The following is a description of a gene set: Human Gene Set: GOBP_REGULATION_OF_ANATOMICAL_STRUCTURE_SIZE species: Homo sapiens Any process that modulates the size of an anatomical structure., and this is the list of marker genes: SLIT2, BAG4, PRKCD, ZFYVE27 (zinc finger FYVE-type containing 27), NTS, TMOD1, ABCC9, SLC12A3, CYFIP2, DOCK5, SERPINF2, ARHGAP5, IRAG1, FGB, HTR2A, CDC42EP5, CDC42EP1 (NCBI Gene Id 129136), TRIM46, CLASP2 (NCBI Gene Id 440948), HCK, APLN, HNF1B, WAS, CCDC51, CFL1, F2RL1, ACTN2, SEMA3F, HCLS1, WASHC5, KXD1, NEB, NGF, AVPR2, PAX2, AVIL, FCHSD2, EXT2, ECE1, BDKRB2, LARS1, SLC8A1, PTPN11, ADD1, GRIP2, SMTNL1, ASXL1, LPAR3, NOS1, ADORA1, CYRIB, BLOC1S1, RAB3B, ISLR2, PAK1, SPTA1, LRRC8A, TRPV4, CPS1, AKT3, PEX11A, MAPT, PER2, ACE2, C15orf62, ROCK1, ARHGAP4, MAP3K13, SLC12A8, TBXA2R, SSH2, PLEK, DRD5, LEP, SOD2, KCNJ8, SEMA3A, RB1CC1, SSH1, MAP2, BLOC1S2, HTR2B, FCHSD1, GCLC, BARHL2, ITGB1BP1, AVPR1A, PLOD3, PECAM1, SWAP70, RAP1GDS1, VILL, KCNA5 (NCBI Gene Id 3741), GOLGA4, TMOD3 (NCBI Gene Id 29766), KIRREL1, FSTL4, KCNMA1, AVP, GSN, SPECC1L, MTNR1B, SOD1, NOS3, SRF, RTN4R, ARHGAP42, KAT2B, GAB1, GCLM, FGF13, CAPZA2, TNFRSF12A, NCK2, NCK1, MAP3K7, ADRB3, ANO6, L1CAM, CDH1, NCKAP1L, SLC12A4, INS, VEGFA, SCT, S100A1, SLC12A6, CCL21, AGT (angiotensinogen), RPTOR, SEMA6C, TBXAS1, MTOR, CAPZA1, ARPC2, ARHGAP28, ARHGAP40, PLEKHH2, P2RY1, RET, MSN, LRRC8E, PREX1, ANAPC2, CXCL12, LMOD1, SCIN, FGA, ARF6, SVIL (NCBI Gene Id 6840), SPTBN4, HRH2, AKT1S1, SEMA6D, LAMTOR4, WDR1, GPX1, TSC1, SCNN1B, SPTB, NTRK3, CARMIL2, SPTAN1, ADD3, SLC12A1, SPART, CASR (NCBI Gene Id 846), LMOD2, LRRK2, STK39, SLC12A7, BAIAP2L2, BAIAP2, FER, EFNA5, CDKL3, FOXC2, CDC42EP4, MMP2 (NCBI Gene Id 4313), MIR214, IQGAP3, ADCY6, WNT5A, RIN3, SLC26A5, RASA1, DISC1, IFRD1, NAA80, ADORA2A, ATP13A2, GBA2, ACE, SLC12A5, FOXC1, SCARB1, GPRC5B, ATP2B1, CALCA, KDM1A, ADCY10, ADRA1A, RGMA, SNX9, TENM1, MIR138-1, IL7R, SLC12A2 (solute carrier family 12 member 2), RNF6, SLC12A9, P2RY2 (NCBI Gene Id 5029), MIR92A1, NPPB, CAV3, SCPEP1, ARFGEF1, EDNRB, GSK3B, PLXNA3, MYO3A, BMPR2, HBB, CDHR2, DNM2, PPARD, KCNMB2, ZDHHC21, SPTBN1, KLF2, SEMA3G, CLCN6, ALS2 (NCBI Gene Id 65058), DRAXIN, KANK2, COTL1, VIL1, ASB2, KEL, CDH4, RAP1GAP2, EPS8, CCL24, NPPA, KIAA0319, LAMTOR5, NPR1, HIP1R, TWF1 (NCBI Gene Id 82712), CAPZA3, UTS2B, ADRB1, DAAM2, WASHC2C, USH1C, ULK1, CNTN2, DLG1, EVL, ADRA2C, SEMA4F, BORCS5, NEFL, SH3BP1, IST1, MTPN, SLIT1, ITGA1, MLST8, CARMIL1, MAS1, ITGA9, RHOA, SEMA4D, SSH3, MRGPRD, P2RX1, HTR1D, ARPC5, ADM, PIK3C2A, SPP1, ADORA2B, FAAH, FSHR, DMTN, GNB3, KCNN4, NHERF1, ACTA2, STUB1, RARG, AVPR1B, AQP4, ROCK2, SNAPIN, CYFIP1, FN1, POU4F2, ARPC3, AGTR2, MEGF8, CCL11, PIK3R2, BCL11A, NKX6-1, MANF, DNAJC16, SEMA5A, BORCS8, PLXNA4, SLC6A4, RYK (receptor like tyrosine kinase), PRKD1, EZR, TMOD4, ATG5, DBH, RAB5A, ELN, WNT3A, KANK1, HSP90AA1, MACF1, SRC, CDKL5, RICTOR, BBS2, F2R, TRIOBP, CD38, DSCAM, ATP1A2, RGS2, BDNF, GRB2, RAB22A (NCBI Gene Id 57403), PTEN, HTR7, WNT7A, PTPRS, AGTR1, CDHR5, RTN4, XK, MAP1B, TWF2, TNR, PYCARD, SHTN1, KANK4 (NCBI Gene Id 388637), CRABP2, TACR1, MYADM, OLFM1, DEPTOR, MKKS, HTR1B, DRD1, RUFY3, UTS2R, ELAVL1, WNK1, NPPC, ARHGAP18, NPHS1, PDXP, PUM2, KCNMB4, CRACD, MYO3B, MAP2K1, ARPC5L, WNT3, ITGB1, VASP, HRH1, FLII, MIR21, DIP2B, KNG1, HDAC6, ALOX15, CDC42EP3, VAV3, SVEP1, GJA5, UCN, GPER1, PEX11B, BORCS6, CLCN3, BRK1, VSTM4, UTS2, BAIAP2L1, DNM1, AP2M1, CAV1, ASIC2, NRP1, RDX, APOE, WNT9B, CLN8, ADRA1B, ADNP, BIN1, EPHA7, EDN3, WNT7B, RAC1, PLEKHG2, HTR1A, COL6A1, ADRA1D, LIMK1, NRCAM, NTN1, DCC, ADRA2A (adrenoceptor alpha 2A), WNK3, CYRIA, OXSR1, LATS1, BBS4, CHMP3, ENSG00000274276, CAPG, BORCS7, WDTC1, SIN3A, ABCB8, CORO1A, TP73, ADRB2, PTK2B, ITGA4, TMSB4Y, RAB21, MAG, TMOD2, PRR16, GDI1, LMOD3, SPTBN5, KCNK6, TNF, ULK2, SPTBN2, CLNS1A, ARHGAP35, SMURF1, NCKAP1, PLS1, HP1BP3, CFL2, ADRA2B, AQP11, PFN3, CCL26, CDK5, FGG, COMP, MT3, PFN1, EDNRA, EDN2, PRKCE, EDN1, PAFAH1B1, RND2, ABITRAM, GUCY1A1, NPM1, PFN2, PICALM, E2F4, VAV1, KANK3, CBS, ADD2, ESAM, CTTN, PAK3, PRKG1, ABL1, TRPM4, BLOC1S6, PEX11G, CAPZB, CCR7, TMSB4X, HNF1A, AMOT, P2RX7, VAV2, PIK3CA, CLN3, TRPC5 (NCBI Gene Id 7224), SCTR, TTL, HAX1, MIR153-1, CDC42EP2, CSF3, DOCK4, TRPV2, DSTN (destrin, actin depolymerizing factor), OXTR, CREB1, CRP, SEMA7A, EXT1, AQP1, SHANK3, LIMA1